Given this list of marker genes CSNK1G2, CHST7, PLPBP, SLC25A4, EPHX1, TSC1, NAA10, RAP2B, SPMAP2, MANSC1, SLC38A3, RAB1B, COX4I1, EXOC4, UBALD1, POLD2, FANCL, NUDCD2 (NudC domain containing 2), ALDH1B1, SS18L2, LPGAT1, VPS13C, RPS6, DDX18, MROH1, TRIB1, ENC1, OPN3, ATG7, ATP1A3, B3GNTL1, UCN, LSM5, LDHA, P2RY12, UXT, TMEM41A, NCKIPSD, TIMM8A, EMC10, F5, TSPAN12, EIF3A, HEMK1, COL1A2, STK11IP, SASH3, PRDX4, RPL4 (ribosomal protein L4), ZNF706 (NCBI Gene Id 51123), ARHGAP1, ABCB9, RARG, PSME1, FOXO3, MRTFA, SAP18, ENTPD1, MPHOSPH6, RENBP, MMP19, RAI1, CLUH, RBMX2, MAP2K3, HMGN3, AP1G2, MCM4, GPATCH1, IL4I1, INTS1, ERG, SFXN1, PUF60, GRN, GATAD2B, BRMS1, RGS18, TEDC1, CNP, EEF1B2, POLR2E, TAF1C, CLMN, SAPCD1, UQCRC2, PPP2R5D, HSPBP1, TCEAL9, TFB2M, RASGRP4, KIFC1, SS18 (NCBI Gene Id 6760), GNL3, LMAN2, ZMAT3, DDX54, CDC6, SSBP4, SEM1, MACROH2A1, NT5C, UXS1, CDCA5, AATK, IL17RA, PNPO, NSMCE2, PLXDC1, TBC1D22A, GFRA3, HCST, FAM120A (family with sequence similarity 120 member A), CRTAP, PIP5KL1, DHX16, NUCKS1, UBE2R2, DAZAP2, ANKRD13A, GSTK1, DOLPP1, ARPC2, TNPO1, SNRPG, NOP58 (NCBI Gene Id 51602), ATP5IF1, C5orf22 (NCBI Gene Id 55322), PLEKHO2, VPS11, PLPP2, SRSF3, IRF6, ZFP36L2, ACY1, CTNNBIP1, GFRA2, FAM13B, RPLP2, VEGFB, NAP1L1, ELP1, SERPINB1, ATF6, TPCN1, ARPC5, COL8A1, PNPLA7, MTX1, COPRS, FMC1, LSR, LAMC2, SIRT7, SLC35A2, EXOSC8, NDUFB10, KXD1, DNAJC5, MCTS1, BTK, AVP, DEPDC7, LSM4, LFNG, UBL7, PPP1R18, NHP2, SDHC, MRPL4, UTP20, CACNA1F, SLC50A1, CEP57L1, ID1, IL4R, PDE1A, PABPC4, HRH2, POLR2A, DGLUCY, KRAS, WNK1, ALYREF, RPS6KA4, VPS9D1, PRKAG2, ARF6, ARHGAP17, FLT1, SIGIRR (single Ig and TIR domain containing), PHKA2, VPS29, SLU7, TWF2, SDSL, RFC1, DOCK1, LIPG, KRTAP3-3, here is a description of the gene set: Genes up-regulated in comparison of dendritic cells (DC) stimulated with Gardiquimod (TLR7 agonist) at 0.5 h versus those stimulated with Gardiquimod (TLR7 agonist) at 24 h. from publication Amit I, Garber M, Chevrier N, Leite AP, Donner Y, Eisenhaure T, Guttman M, Grenier JK, Li W, Zuk O, Schubert LA, Birditt B, Shay T, Goren A, Zhang X, Smith Z, Deering R, McDonald RC, Cabili M, Bernstein BE, Rinn JL, Meissner A, Root DE, Hacohen N, Regev A (PMID 19729616) studied in species Homo sapiens Human Gene Set: GSE17721_0.5H_VS_24H_GARDIQUIMOD_BMDC_UP mouse primary BMDCs were stimulated with tlr ligands and gene expression changes were profiled on Affymetrix arrays